Given this list of marker genes FRAS1, FREM2, GRIP1, MYH3, ALX4, PORCN, here is a description of the gene set: Cleft ala nasi Human Gene Set: HP_CLEFT_ALA_NASI species: Homo sapiens The presence of a notch in the margin of the ala nasi.